Given this list of marker genes Terf1, Rpa1, Rpa3, Blm (Bloom syndrome, RecQ like helicase), Terf2ip, Pold4, Pold2, Pold3, Acd, Wrn, Pcna, Dna2, Pot1a, Lig1, Rpa2, Terf2, Fen1, Pold1, here is a description of the gene set: Processive synthesis on the C-strand of the telomere studied in species Mus musculus Mouse Gene Set: REACTOME_PROCESSIVE_SYNTHESIS_ON_THE_C_STRAND_OF_THE_TELOMERE